The following is a description of a gene set: Mouse Gene Set: GOMF_L_AMINO_ACID_TRANSMEMBRANE_TRANSPORTER_ACTIVITY Enables the transfer of an L-amino acid from one side of a membrane to the other. L-amino acids are the L-enantiomers of amino acids. species: Mus musculus, and this is the list of marker genes: Slc38a8, Slc17a8, Slc1a4, Slc1a5, Slc7a2, Slc38a11, Slc1a1, Slc25a12, Slc36a4, Slc7a13, Slc6a20a, Slc7a7, Slc7a10, Slc1a6, Slc25a13, Slc17a7, Ctns, Slc7a11, Slc47a2, Slc66a1, Slc43a2, Slc3a2, Slc36a1, Sfxn3, Slc43a1, Slc1a7, Slc38a3, Slc17a6, Slc7a8, Slc25a2 (solute carrier family 25 (mitochondrial carrier, ornithine transporter) member 2), Ucp2, Slc36a2 (NCBI Gene Id 246049), Slc38a1, Slc38a9, Slc7a5, Slc7a1, Slc13a3, Slc16a10, Slc7a6, Slc47a1, Slc7a15, Slc38a7, Slc38a10, Slc38a2, Slc1a3, Slc25a18, Slc7a12, Slc38a5, Slc6a20b, Slc25a15, Slc25a22, Slc6a7, Grik1, Slc25a26, Nat3, Sfxn1, Slc25a29, Slc15a4, Slc22a2, Slc38a4, Slc7a9, Slc7a3, Slc38a6, Slc1a2, Slc36a3